The following is a description of a gene set: A SWI/SNF-type complex that contains a bromodomain containing-protein, such as yeast Rsc1 or Rsc4 or mammalian PB1/BAF180. The RSC complex is generally recruited to RNA polymerase III promoters and is specifically recruited to RNA polymerase II promoters by transcriptional activators and repressors; it is also involved in non-homologous end joining. studied in species Homo sapiens Human Gene Set: GOCC_RSC_TYPE_COMPLEX, and this is the list of marker genes: ACTL6A, SMARCE1, SMARCC1, ACTL6B, BRD7, PHF10, SUZ12, SMARCA4, ARID2, PBRM1, ACTB, SMARCD1, SMARCB1, SMARCC2, SMARCD2